The following is a description of a gene set: part of: Diseases of the urea cycle Carbamoyl phosphate synthetase 1 (CPS1) deficiency (OMIM 237300) is a rare autosomal recessive disorder that impairs the urea cycle, leading to hyperammonemia and potential neurological damage if untreated. Clinically, CPS1 deficiency presents with a spectrum of severity, ranging from neonatal-onset hyperammonemia to later-onset episodes triggered by metabolic stress. Early diagnosis and management are crucial to prevent irreversible neurological damage.<br>The CPS1 enzyme, located in the mitochondrial matrix, catalyzes the first and rate-limiting step of the urea cycle: the synthesis of carbamoyl phosphate from ammonia, bicarbonate, and ATP. This reaction is essential for the detoxification of ammonia in the liver.<br>Synthesis of carbamoyl phosphate by human CPS1 occurs in three linked biochemical steps. In the first step, ATP-dependent phosphorylation of bicarbonate yields the unstable intermediate carboxyphosphate. In the second step, carboxyphosphate reacts with ammonia to produce the next unstable intermediate, carbamate. In the final step, ATP-dependent phosphorylation of carbamate yields carbamoyl phosphate. Enzyme activity depends on the binding of the allosteric activator N-acetyl L-glutamate (NAG) to its binding domain in the C-terminal.<br>Various functional domains contribute to the enzymatic activity and stability of the protein. The N-terminal region consists of a N-terminal extension of unknown function and the inactive glutaminase domain; these regions may contribute to overall structure and stabilization of the active conformation. The bicarbonate and carbamate phosphorylation domains are separated by an "integrating domain" (ID) that contributes to the structural integration of CPS1, influencing enzyme folding and stability and providing a tunnel for the carbamate to transfer between the two catalytic sites. Mutations in this domain can lead to misfolding and reduced enzyme activity. The C-terminal NAG binding domain binds the essential activator of CPS1; in consequence, any CPS1 nonsense mutation that precedes this domain is effectively non-functional.<br>Over 270 mutations have been identified in the CPS1 gene, with a predominance of missense mutations affecting various domains. Notably, mutations in the bicarbonate phosphorylation domain, the integrating domain and the NAG-binding domain are more likely to result in severe clinical manifestations due to their direct impact on enzyme function (de Cima et al, 2015; Yan et al, 2019; reviewed in Martinez et al, 2010)<br> species: Homo sapiens Reactome Pathway: CPS1 variants cause CPS1 deficiency, and this is the list of marker genes: CPS1